The following is a description of a gene set: Mouse Gene Set: GOBP_PHOTORECEPTOR_CELL_MORPHOGENESIS species: Mus musculus The process in which the structures of a photoreceptor cell are generated and organized. This process occurs while the initially relatively unspecialized cell is acquiring the specialized features of a photoreceptor cell, a sensory cell that reacts to the presence of light. An example of this is found in Drosophila melanogaster., and this is the list of marker genes: Bbs1, Cdhr1, Grk1, Ift56, Rabl2, Cfap418, Mfsd2a, Cabp4